Given this list of marker genes Fip1l1, Lsm11, Slbp, Papola, Snrpf, Wdr33 (WD repeat domain 33), Clp1, Cpsf3, Zfp473, Snrpg, Cpsf1, here is a description of the gene set: This event has been computationally inferred from an event that has been demonstrated in another species.<p>The inference is based on the homology mapping from PANTHER. Briefly, reactions for which all involved PhysicalEntities (in input, output and catalyst) have a mapped orthologue/paralogue (for complexes at least 75% of components must have a mapping) are inferred to the other species. studied in species Mus musculus part of: RNA Polymerase II Transcription Reactome Pathway: RNA Polymerase II Transcription Termination electronically inferred by orthology from the curated human pathway